Given this list of marker genes TBC1D32, FKBP8, FOXA1, SMO, BMP4, WNT3A, RNF220, TULP3, GSC, PTCH1, WDR19, GLI3, SHH, PSEN1, GPR161, TCTN1, PAX7, here is a description of the gene set: The process in which the neural tube is regionalized in the dorsoventral axis. Human Gene Set: GOBP_DORSAL_VENTRAL_NEURAL_TUBE_PATTERNING species: Homo sapiens